The following is a description of a gene set: species: Mus musculus Any process that results in a change in state or activity of a cell (in terms of movement, secretion, enzyme production, gene expression, etc.) as a result of a magnesium ion stimulus. Mouse Gene Set: GOBP_CELLULAR_RESPONSE_TO_MAGNESIUM_ION, and this is the list of marker genes: Smpd3, Kcna1, Kcnj1, Ank3, Slfn14, Slc41a1, Fbp1, Ryr3